The following is a description of a gene set: Any process that stops, prevents or reduces the frequency, rate or extent of autophagosome assembly. studied in species Mus musculus Mouse Gene Set: GOBP_NEGATIVE_REGULATION_OF_AUTOPHAGOSOME_ASSEMBLY, and this is the list of marker genes: Ehmt2 (euchromatic histone lysine N-methyltransferase 2), Mtm1, Nupr1, Smcr8, Phf23 (NCBI Gene Id 78246), Fez1, Tmem39a, Scfd1, Sec22b, Fez2, Becn1 (beclin 1, autophagy related, NCBI Gene Id 56208), Lrrk2, Pink1